Given this list of marker genes RAD21L1, TM9SF1, ZNF391, DARS2, SLC1A7, TRIB1, GBA3, INTS14, RPL34, MAGIX, TIA1, TFPI2, CCAR2, SLC14A2, ALDH4A1, PKNOX1, DST, SELENOP, ZNF318, APH1B, LIPA, PRMT8, KLRA1P (NCBI Gene Id 3819), PIAS2, PTPRC, STARD13, EGR2, BCL2L2, CHMP1B, E2F2, IGLJ3, TFAM, GEMIN4, H3-4, TRPM8, TDRD1, CANX, HNRNPA3P1, CLCN6, PNOC, PPY2P, PSORS1C1, ALDOC, AFAP1, IL17RB, ITPR1, XPO7, CYFIP1, IL6ST, SSTR1, CYP4F8, NFYC, ARL2BP, GFPT1, GNRH1, CT62, UTY, TUBA3D (tubulin alpha 3d), PECAM1, CZIB (CXXC motif containing zinc binding protein), TCTN2, ROBO1, CNNM4, GOLGA1, PITX2, CEP162, MYF5, SGSH, IL5, TRIM2, FAM182B, NR5A2, ZNF16, MTMR12, GCKR, ELL2, CDK3, TLK2, ABCB1, KLF4, PRSS21, SCHIP1, RPS2, ANKRD6, GPR63, MAFF, DES, ZC2HC1A (zinc finger C2HC-type containing 1A), ASRGL1, MTRF1, RNFT1, CRYBB1, DIO3, LCP1, ELP3, ZNF174, ARNT, DDX18, VEGFA, DCUN1D2, TSPAN13 (NCBI Gene Id 27075), HOXB9, FANCC, PABPC1, DCLRE1B, PEX5, ATXN10, SLC37A4, SOAT2, HIPK2, PRDM1, GK (NCBI Gene Id 2710), LDLRAP1, TMEM242, C1R, TMEM43, DLAT, PCYT1A, IPO8, NECTIN1, HLA-DRB6 (major histocompatibility complex, class II, DR beta 6 (pseudogene)), PXMP4, ASTN2, DSE, SERINC3, GGA2 (golgi associated, gamma adaptin ear containing, ARF binding protein 2), RBPJL, DHRS12, AKAP8, CLIP4, VPS39, TXNIP, ACE, H4C9, GNA13, KCTD20, HILPDA, GPT, DNAAF1, SHOX2, ZNF549, NEUROG3, COQ7, CWC25, FAM120C (family with sequence similarity 120 member C), SLC22A5, CLCN2, DHRS1, PTGDR2, AADAC, CTAGE9, EREG, TCAF1, MYO16, ZDHHC8BP, PAQR5, C11orf21, NEK3, GPR15, RFX3, CST2, SLC18A2, AHSP, PEPD, THG1L, ZNF516, CENPJ, ACAN, ERMP1, SNRPN, ADK, TRPC1 (NCBI Gene Id 7220), PRKAR2B, CHTOP, UTP25, STAG3 (NCBI Gene Id 10734), TNFRSF4, FAM131B, PDP1, GRAMD1B, UBE2Z, ZIC4, ZNF214, PPIAL4A, CEP97, RIMS2, FPR2, ZNF207, PHKA2, FAM186A, PNLIPRP2, UCN, XK (X-linked Kx blood group antigen, Kell and VPS13A binding protein), PPAT, RBPJ, TRDV2, EEA1, RFPL1S (NCBI Gene Id 102723305), UBQLN3, here is a description of the gene set: Human Gene Set: GSE35435_RESTING_VS_IL4_TREATED_MACROPHAGE_DN species: Homo sapiens Genes down-regulated in macrophages: resting versus stimulated by IL4. from publication Martinez FO, Helming L, Milde R, Varin A, Melgert BN, Draijer C, Thomas B, Fabbri M, Crawshaw A, Ho LP, Ten Hacken NH, Cobos Jiménez V, Kootstra NA, Hamann J, Greaves DR, Locati M, Mantovani A, Gordon S (PMID 23293084) Analysis of alternative activation of macrophages at gene expression level. The study forms part of a wider study where we compare the effects of IL-4 in different human and mouse macrophages. Our results support the notion that in vitro culture conditions greatly affect the macrophage response to IL-4. Total RNA obtained from bone marrow derived macrophages upon exposure to 20 ng/ml of IL-4 for 18 hours.